Given this list of marker genes BCKDK, IRF7, PDCD2, ABHD16A, GAL3ST4, LSS, ABCB1, PRMT5, SYNGR1, DTD1, RAB8B, MRPS18B, SLC4A9, VPS11, USP4, SLC30A9, MAN1C1, VAPB, ALOX15 (NCBI Gene Id 246), FBXW9, IQGAP3, VKORC1, CD27-AS1, COMT, EPAS1 (endothelial PAS domain protein 1), B3GNT8, TMEM165, OXCT1, LMO7, ARFGEF2, LRP1, GPR83 (G protein-coupled receptor 83), ARHGAP25, OASL, HES6, PRSS50, ATP2A3, MARCHF11, GALC, LGALS1, SEMA4D, TMEM150C, LY9, TIFAB, FCGR3A, SLC46A1, YEATS4, IGFBPL1, SULF2, FOLR2, RAB20, TLR8, GAS6, CCT8, EEF1D, DNAH6, PEX14, BLNK, TMEM86A, ATP1A1, TINAGL1, TRMT1 (NCBI Gene Id 55621), UQCRC1, BHLHE40, DHCR7, STARD3, NPEPL1, SLC24A3, THAP4, MNT, MSMO1, NTN4, UBE2Q1, INHBB, SLC36A2, PRKCB (protein kinase C beta), WSB2, FAM117A, IDH2, RRAGD, ADA, FKRP, TTC28, FAP, TPGS1, METTL18, BAD, ABCC3, DCAKD, SCARA3, TRAF3IP1, MANF (NCBI Gene Id 7873), SERPINA1 (NCBI Gene Id 5265), INF2, CAMKK1, HRAS, GCSH (NCBI Gene Id 2653), ABTB1, DTNBP1, AKR1E2, TLCD2, APOBEC1, SPG21, PXT1, RHOBTB2, ST8SIA4, NUTF2, SHC3, TBCC, PKD1L2, SPICE1, NPTX1, APRT, RAP1GAP2, PLD4, RPL9, TMEM184B, RILPL2, SLC11A1, RLBP1, TMEM202, TMEM37, LPXN, MFSD12, DHRS3, SMAD3, LRP12, A2M, INHBE, GADD45G, SNRPB, SPNS1, APOE, OTOP3, WDR41, CYP26B1, ABHD12, GABARAPL1, HHAT, PLA2G15, DPH5, ALKBH7, COL14A1, KCNJ10, PDXK, IFI30, LAMTOR1, ITM2B, TSPAN1, MGAT1, SLC39A12, PEF1, GPC1, IDI1, CARD10, SERTAD4, WDSUB1, SPEF1 (sperm flagellar 1), NMT1, DCAF12L1, HMGCS1, NLRP4 (NCBI Gene Id 147945), PRSS21, AP1B1, CD300LB, NCKIPSD, FILIP1, TBXAS1, EDAR, GPNMB, LIG1, ATP23, NRIP1, RARB, UBE2O, KCNK13, STX7, PISD, IDH1, MECR, TRIM47, RFX2, ANAPC2, KLF15, RPL3, NDUFA3, LIPA, KIAA0513, NDST1, LHCGR, CAMK2N1, CCT7, MYH10 (NCBI Gene Id 4628), HMOX2, POU6F2, CRIP1, RPS7, ORAI3, GPX8, EEPD1, here is a description of the gene set: Human Gene Set: GSE2585_AIRE_KO_VS_WT_CD80_LOW_MTEC_DN Genes down-regulated in medullary thymic epithelial cells (mTEC) with CD80 low: AIRE knockout versus wildtype. from publication Derbinski J, Gäbler J, Brors B, Tierling S, Jonnakuty S, Hergenhahn M, Peltonen L, Walter J, Kyewski B (PMID 15983066) species: Homo sapiens Gene expression in different thymic stromal cells and subsets thereof was analyzed in 6-12 week old wild type (C57BL/6) and Aire knock-out (mixed background) mice. Thymic stromal cells were purified by sequential enzymatic digestion (collagenase, collagenase/dispase and trypsin) followed by gradient centrifugation and FACS sorting. Sort criteria were as follows: dendritic cells (CD11c+, F4/80 -), macrophages (F4/80+, CD11c-), cTECs (CD45–/lo, CDR1/Ly51+, Ep-CAM+) and mTECs (CD45–/lo, CDR1/Ly51–, Ep-CAM+). mTECs of wild-type and Aire knock-out mice were further subdivided according to CD80 expression levels. For microarray analysis total RNA from thymic stromal cell samples of two independent experiments was pre-amplified and biotinylated by two rounds of cDNA synthesis and in vitro transcription. Fluorescence readings were evaluated by using Microarray Suite 5.0 software.